Given this list of marker genes TBC1D9B, ANO10, OAS1, NIPSNAP1, NCAPG, UPF1, RANBP9, GTF3C1, CIR1, MAP2K5, MOGS (mannosyl-oligosaccharide glucosidase), PLA2G2A, AASDHPPT, ECHDC2, SLC17A5, PTPN6, VPS13C, IFT122, DOCK9 (dedicator of cytokinesis 9), PYGL, SKAP2, SLC35C2, GLG1, FLRT1, GRHPR, KLF12, HECTD3, BTD, EML3, AMBRA1, GATB, PRRC2B, SLC25A38, PCIF1, USP34, KCNK1, NPRL2, CSNK1A1, PTBP1 (polypyrimidine tract binding protein 1), CTBP2, INTS6, ANXA13, APEX2, CEBPA, MCM4, RAB11FIP3, ITGA7, GBF1, GOSR2, ENPEP, VAT1, BBS4, CLSTN1, ZCWPW1, MKS1 (NCBI Gene Id 54903), COPG1, MAP3K5, EDA, PSD4, EXOC3, EHMT2, BCAS3 (BCAS3 microtubule associated cell migration factor), RESF1, PEX6, GSTT1, MTOR, SGSM3, MYO15B, CSTPP1, HOPX, JAK2, ZER1, IQCG, KIR2DL5A, PANK4, DHCR7, RORA, DBT, ADA, CLK2, TM9SF4, ATXN7L1, HADHA, IQGAP1, FANCG, PDK3, UNC45A, SNTB1, TTC38, MAGEC2, CASKIN2, PDCD4, HADHB, CATSPER2, WDR48, DHX30, SLC4A4, NCAPH2, DYRK4, VAMP4, FABP4, KLHL20, PIWIL2, ECI2, IFT46, GALT, CTH, PIP5K1C, ATP6V0E1, CRYL1, TBC1D8B, USP47, HDHD5, IFI16, TRPM2, MDH2, SULT1A2, CYP46A1, AGER (advanced glycosylation end-product specific receptor), NBR1, YIPF3, MPDZ, SRGAP2, NFX1, TRIM52-AS1, CAPG, RBMY2AP, RTN1, ASXL1, ARL3, IRAK4, CYP4F11, MADD, TAB1, MYO1C, RECQL4, SLC22A1, DDIT4, PI4KA, NSDHL, SYNE2, SUPT5H, TMEM8B, MAST2, CAPN15, TRIOBP, SP110, ZNF710-AS1, HLA-DRB4, ME3, RBFA, RBM5, SMARCD1, PIAS1, ATP6AP2, CSRP2, ATXN1, TNFRSF1A, CEP350, DHX57, PBX2, ZMYM5, TEAD1, PPARD, SRRT, DNAI4, DNAJC3, EZH1, SNRNP70, RXRB, PDE4DIP, FLII, ARNT, PRODH2, PMM1, F2RL1, ATF7IP, PAPSS1, DDO, CBLB, AP2A2, SLC25A4, TNRC6B, GAS2, ARHGAP26, SSX5, FGB, CDK12, SERGEF (NCBI Gene Id 26297), SREBF2, FKBP1A, G0S2, RPP21, SHMT2, PLAG1, TSHZ2, ING1, ACOX1, TNFSF13, DHRS12, MYO1D, UBE2L3, SERPIND1, CTNND1, SRPX (sushi repeat containing protein X-linked), CDK18, LRP1, MFSD10, STAT1, TFPI (tissue factor pathway inhibitor), AIM2, VPS13D, USE1, AKAP13, TCF25, KLHL9, KCTD2, CIDEC, EPB41L4A, DOCK6, CHMP1B, ARRB1, CHD4, CTNNB1, HLA-DRB1 (major histocompatibility complex, class II, DR beta 1), FAM120C, TCF4, MLYCD, AP3B1, FKBP1B, ZKSCAN5, FADD, EFNA4, UBTD1, LAMA2, TRADD, OASL, KAT6A, RPGR, FCGRT, MED18, ZNF34, HSPA4, HMGCS1, SMPD1, TRIM45, COMMD10, TFF3, MVD, COPZ1, EIF5A, PTPN18 (NCBI Gene Id 26469), KAT6B, HPS4, CITED2, KDM5A, AGFG2, APOM, DES, INTS9, GPHN, HEATR6, NCKAP1L, SYT1, GMPR, IQCE, NCKIPSD, ABCD4, LAMB3, GLRX, CLEC2B, KLF3, CDK5RAP3, ETHE1, GYG2, PRKAR1A, PEPD, TOP3A (NCBI Gene Id 7156), PSPH, NADSYN1, VAPB, DNAJC17, CACTIN, ALDH7A1, H4C14, CDO1, EHD2, TRANK1, RNGTT, SNAPC3, EFL1, CRYGD, TNFRSF11B, IL17RC, HAUS5, ZMYND8, PRKD1, CD44, GPR153, CP, ADM, CPM, TBC1D22A, TSFM, OGA, PSIP1, FDPS, CD63, DENND2B, IL13RA2, OTUB2, VPS11, CYTH4, MAP3K6, THNSL2, PPP1R7, PPDPF, RBM48, TF, ACYP1, AHCYL1, PDE6D, CD86, CREBL2, RSL1D1, TINF2, CASP8, CAST, PNRC1, NDUFS1, SAP18, CDC40, ZNF557, CYP4F12, L2HGDH, RCBTB2, RAB5B, DUS1L, MSRB1, TNFRSF10C, MRPS27, DNAJA4, SEC22B, ZNF142, PECAM1, SEPTIN4, HSD17B2, SASH1 (SAM and SH3 domain containing 1), PCBP2, PTPRA, DEPDC5, STRA6, CHD1L, GIT2, DBP, BNIP3L, PPIE (NCBI Gene Id 10450), GPR137, ELOB, OSGEPL1, GSTT2, COQ6, KDM4B, DNAAF1, PLCB1, MAGEC1 (NCBI Gene Id 9947), PMS2, RBM10, SUPT6H, PRKAG2, RDX, TSC2, PDK4, SYNE1, ZNF324B, EEF2, CTDP1, PPIG, CRYGS, BGLAP, NRDC, FAF1, SLC39A7, ALDH4A1, CYP4F2, EFNA1, PLCG1, MIR9-1HG, GNAS, SDHA, EIF3C, ELP4, NAB2, ALAD, EVL, LIAS, UBL4A, DRD2, CALCOCO1, LYPLA2, POLG, SLC11A2, PHF3, FAM174B, RGP1, PECR, CABIN1, CD53, CRADD, FARP1, ODR4, ASB13, ESRRG (estrogen related receptor gamma), SKP1, RBM19, AIFM1, TXNRD3, CUL9, IP6K2, CEBPD, LYRM9, GABARAPL1, IFT140, ITGA10, CYP2A6, DGLUCY, ACOX3, FN1, PGAP2, CCNG2, HMGCL, BCHE, DELE1, MYO9B, UBE4B, MAP2K6, CYB561, TANK, C10orf95-AS1, PAFAH2, ALAS1, VEGFB, MAGEA5P, TPGS2, SUPT4H1, TUBG2, NUP188, PPP3CA, ZFTRAF1, IDH3B, P4HTM, WWOX, CCHCR1, TNFSF10, KATNIP, WRAP73, OXR1, ALDH3A2, DLST, PDK2, XPO6, PCCA, DGKH, CTDNEP1, NONO, CEP250, LTBP1, IL1R1, AKR7A2, CD40, SIX2, DHFR, THADA, PHKG2, CNNM2, DHODH, MSRB2, MSH3, PEX5 (peroxisomal biogenesis factor 5), BRWD1, MAZ, SLIT1, PLOD1, PCDH9, RAB3GAP1, DPH1, RHEB, ARL4C, SEMA3A, NPEPPS, SLC27A3, F11, SEMA4F, TSPAN31, NCBP2, PRDX2, NBAS, RNASET2, THBS3, IGFBP1, SMARCA2, BIN1 (bridging integrator 1), PPARA, EID1, C1QTNF1, PRKAR2A, CPQ, PDE4A (phosphodiesterase 4A), SLC6A8, ECHDC3 (enoyl-CoA hydratase domain containing 3), FAM13A, SCRIB, HDAC6, TECPR2, PSMC5, SAMD9, SLC25A28, LHPP, RECQL, CPT2, AKR1C4, RNF41, NSD1, SSX2, HELZ, ADCY9, RTEL1, MAP3K3, MIA, RNF123, RIC8B, TNFRSF25, DIP2A, EIF2B5, DCTN5, SIRT3, ELF3, GUSBP3, LIG1, TPCN1, GCDH, CPSF1, TMC6, HPN, PRUNE1, RCE1, TSC22D3, DHX9, SPAG9, CYP19A1, NASP, ADCY8, PDHA1, TMEM53, CASP9, SVIL, NPIPB15, CAPN7, GTF2H3, PHGDH, ST6GAL1, TMBIM6, PRIM2, OSER1, PSMF1, RAD50, GLUD1, SURF1, PCK2, here is a description of the gene set: The mammalian target of rapamycin (mTOR) pathway, a major regulator of translation, is frequently activated in hepatocellular carcinomas. We investigated the effects of mTOR activation in the human HepaRG cells, which possess potent hepatocytic differentiation capability. Differentiation of HepaRG cells into functional and polarized hepatocyte-like cells correlated with a decrease in mTOR and Akt activities. Stable cell lines expressing an activated mutant of mTOR were generated. Sustained activation of mTOR impaired the hepatocytic differentiation capability of these cells as shown by impaired formation of bile canaliculi, absence of polarity, and reduced secretion of alpha1-antitrypsin. An inhibitor of mTOR, rapamycin, was able to revert this phenotype. Furthermore, increased mTOR activity in HepaRG cells resulted in their resistance to the antiproliferative effects of transforming growth factor-beta1. Profiling of polysome-bound transcripts indicated that activated mTOR specifically targeted genes posttranscriptionally regulated on hepatocytic differentiation. Three major biological networks targeted by activated mTOR were identified: (a) cell death associated with tumor necrosis factor superfamily members, IFNs and caspases; (b) lipid homeostasis associated with the transcription factors PPARalpha, PPARdelta, and retinoid X receptor beta; and (c) liver development associated with CCAAT/enhancer binding protein alpha and hepatic mitogens. In conclusion, increased mTOR activity conferred a preneoplastic phenotype to the HepaRG cells by altering the translation of genes vital for establishing normal hepatic energy homeostasis and moderating hepatocellular growth. studied in species Homo sapiens Genes up-regulated in HepaRG cells (liver cancer) expressing constituvely active form of MTOR. Human Gene Set: PARENT_MTOR_SIGNALING_UP from publication Parent R, Kolippakkam D, Booth G, Beretta L (PMID 17483347)